The following is a description of a gene set: Genes up-regulated in common dendritic cells versus those cultured and untreated. species: Homo sapiens Human Gene Set: GSE22432_CDC_VS_COMMON_DC_PROGENITOR_UP Dendritic cells (DCs) in lymphoid tissue comprise conventional DCs (cDCs) and plasmacytoid DCs (pDCs) that develop from common DC progenitors (CDPs). CDPs are Flt3+c-kitintM-CSFR+ and reside in bone marrow. Here we describe a two-step culture system that recapitulates DC development from c-kithiFlt3-/lo multipotent progenitors (MPPs) into CDPs and further into cDC and pDC subsets. MPPs and CDPs are amplified in vitro with Flt3 ligand, stem cell factor, hyper-IL-6 and insulin- like growth factor-1. The four-factor cocktail readily induces self-renewal of MPPs and their progression into CDPs and has no self-renewal activity on CDPs. The amplified CDPs respond to all known DC poietins and generate all lymphoid tissue DCs in vivo and in vitro. Additionally, in vitro CDPs recapitulate the cell surface marker and gene expression profile of in vivo CDPs and possess a DC-primed transcription profile. Transforming growth factor-β1 (TGF-β1) impacts on CDPs and directs their differentiation towards cDCs. Genome-wide gene expression profiling of TGF-β1-induced genes identified transcription factors, such as interferon regulatory factor-4 (IRF-4) and RelB, that are implicated as instructive factors for cDC subset specification. TGF-β1 also induced the transcription factor inhibitor of differentiation/DNA binding 2 (Id2) that suppresses pDC development. Thus, TGF-β1 directs CDP differentiation into cDC by inducing both cDC instructive factors and pDC inhibitory factors. from publication Felker P, Seré K, Lin Q, Becker C, Hristov M, Hieronymus T, Zenke M (PMID 20881193), and this is the list of marker genes: MADD, TRPV2, MTA3, RIN3, F2RL1, NRM, MXD4, SYNRG, GYG1, SLC49A4, TUT7, CIITA, ARHGAP15, ANTXR2, RAPGEF2, MTMR6, JAK1, RAPGEF1, H3C14, SYPL1, TRAF3IP2, TAB2, ADGRE5, ULK2, LCP2, CCPG1, TEC, CDC42SE2, H2AC25, SNX29, JMJD1C, ITIH5, TUT4, CFP, TRAF5, SERINC5 (serine incorporator 5), SP4, NOTCH2, CIB1, RIPOR2, ZMYND8, RAB33B, ACYP1, CDC42EP3, POLD1, SMPDL3A, GRHPR, CEP128, NARF, WDR44, CTSO, ZBTB24, ATAD2B, ITGAX, ARID1B, B3GNT8, MGST2, LSP1, INPP5D, SH3GLB1, TSPYL4, GAB3, CDKN1B, UBLCP1, SH3BGRL3, TMEM26, TBC1D10C, PSD4, TAOK3, NDST1, KMT5C, OTUB2, GIMAP5, MAD2L1, ARHGAP45, PSD3, STX2, ARHGAP25, ACTG1, SMG1, HIP1R, RALGPS2, NFAM1, CDH17, RAB39A, RFC2, BBS9, SSBP3, BMP2K, SLC41A2, LYST, NSMCE1, GRB2 (NCBI Gene Id 80715), SLC37A4, COTL1, MAPK14, KLF3, MBNL1, CSRP2, SH3BP1, ALDH2, NEDD9, CCDC71L (NCBI Gene Id 168455), RTN4, SMAP2, CDC42SE1, RELL1, PLEKHG2, TBXA2R, PIERCE2, SELENOO, RCSD1 (RCSD domain containing 1), FES, PCLAF, CHIC2, FANCA, S1PR1, CXCR5, APPL2, RDH12, XKRX, PARP4, SH3PXD2A, RPS21, SLC25A53, BLNK, ZNF821, INSR, MGST1, DNAH8, CAPN2, GPD2, SCD, LGMN, SLC35D2, TMEM86B, TNK2, ZNF592, RFX3, KLHL28, AP1S2, SYNE1, TBC1D9, CPNE5, DERL3, GDI1, UNC119, CSK, GDAP2, GNA15 (G protein subunit alpha 15), COL23A1, ARFGEF2, KLHL6, AFF3, P4HTM, CNKSR3, DHRS7, TSHZ1, TBC1D14, TFEB, RAB4B, CERK, HERC2, CNST, RNF139, HCLS1, SIKE1, CAMK1D, ZCCHC18, KIDINS220, CEP120, MYO18A, SAFB2, KLHL14, OGA (O-GlcNAcase), TMEM64, DGKD, ARHGAP18, FAM107B, SNX14, LXN, PRKACB, ICOSLG, GPAT3, TXNDC16, KCNAB2, GRAMD1A, CKLF, CORO6, FERMT3, SIK1, NDUFB11, ANGPTL1, RELCH (NCBI Gene Id 57614), POU2AF1, ATF3, EMID1, BIRC3, GALNT10, CYTH4